The following is a description of a gene set: studied in species Homo sapiens Human Gene Set: HP_WEAKNESS_OF_FACIAL_MUSCULATURE Reduced strength of one or more muscles innervated by the facial nerve (the seventh cranial nerve). Weakness of facial musculature, and this is the list of marker genes: SLC25A21, DLL4, PIK3CA, SEMA3E, PLXND1, MT-TN, UBA2, PEX6, GLE1, TRIM32, SUFU, KLHL41, PTRH2, SCN1A, LAMB2, SCN4A, MTRFR, SUPT16H, PLEC, SALL4, MSTO1, SGCD, SLC52A2, GAN, ASAH1, MYMX, MB, FRG1, TERT, ZC4H2, TREX1, RYR3, DNM2, TNNC2, RRM1, BTNL2, CFL2, CRYAB, RYR1, PEX26, TOR1A, MYL1, IRF2BPL, HOXB1, CACNA1A, HACD1, VAMP1, DNMT3B, ANKH, BMS1, GIPC1, PEX16, OPA1, DBH, VCP, SIX5, ADA2, GJC2, MGME1, POMT2, ADNP, PEX2, COL6A1, SMARCB1, CHCHD10, SIX1, CADM3, AGRN, STAC3, SYT2, SH3TC2, KIF1B, MYH7, SLC5A7, CHKB, TPM2, FLNC, NOTCH2NLC, CNBP, LRIF1, UBA1, GSN, RAPSN, SMO, CLCF1, SELENON, MAP3K20, SRPX2, PEX10, BAG3, BIN1, NFU1, STAG2, COL12A1, COL6A2, PEX12, SYNE1, ATP1A2, SLC25A42, NF2, ADCY6, PEX19, FKRP, AKT1, MTM1, DPAGT1, PEX1 (NCBI Gene Id 7788), HK1, NEFL, ALG2, LRP5, ACADS, CRLF1, SLC12A6, SQSTM1 (sequestosome 1), FKTN, GJA1, SPEG, XRCC2, LRP12, GMPPB, POLG, GFPT1, KBTBD13, SMCHD1, MPZ, SLC19A3, DUX4, SNAP25, CHRNA1, ITGB4, ITGA7, GDAP1, RILPL1, NOD2, CRPPA, SURF1, CHAT, LMOD3, COL4A1, TNFSF11, COL13A1, EBF3, OSTM1, TK2, LAMA2, ANTXR1 (ANTXR cell adhesion molecule 1), DNM1L, TUBB3, TUBB6, PEX11B, SOST, ALG14 (NCBI Gene Id 199857), COLQ, SCO2, REV3L, DUX4L1, DES, SPTBN4 (NCBI Gene Id 80322), TRAF7, ADGRG1, DCTN1, BAP1, TTN, SLC39A14, DMPK, CHRNB1, TFAP2A, NUTM2B-AS1, MTMR14, CHRNE, PTDSS1, CHD7, EYA1, CHRNG, TPM3, PRRT2 (proline rich transmembrane protein 2), PEX5, CHRND, SLC25A1, POLG2, PABPN1, LARGE1, TCIRG1, BICRA, PUF60, NARS2, MTMR2, POMT1, MUSK (muscle associated receptor tyrosine kinase), ANXA11, SLC25A4, PEX13, CAPN3, CLCN7, MEGF10, LRP4, ANO5 (anoctamin 5), ACTA1 (NCBI Gene Id 58), TWNK, JAG2, KMT2D, MYPN, TRPV4, MYMK, RNASEH1, RRM2B, ACTN2, SBF2, UBE2T, AMER1, PEX3, SMARCE1 (NCBI Gene Id 6605), YARS1 (tyrosyl-tRNA synthetase 1), PI4KA, SNX10, TNNT1, KLHL40, MYL2, DNAJB6, YME1L1, MYO9A, GNE, PDGFB, SNUPN, COX6A2, TGFB1, KY, CNTNAP1, SLC52A3, HLA-DRB1, ABCA1, NEB, AK9 (adenylate kinase 9), SUCLA2, MT-TE, DOK7 (NCBI Gene Id 619409), PEX14, SHMT2, SLC18A3, ADSS1, ITPR1